Given this list of marker genes Anxa1, Pla2g1b, Abcc1, Drd4, Tnfrsf11a, Nmur2, Lhcgr, Cyp4a32, Ptges, P2rx7, Pla2g2d, Atp5pf, Hrh3, Cyp4a10 (NCBI Gene Id 13117), Abcc3, Pnpla8, P2ry2, Kiss1r, Nos2, Sstr4, Lep, Mapk9, Slco3a1, Slc22a1, Slc22a8, Pla2g4a, Pla2r1, Agtr2, Pla2g12b, Pla2g4f, Slc22a22, Ntsr1, Abcc10, Tnfsf11, Pla2g2e, Oc90, Pla2g12a, Syk, Il1a, Pla2g6, Cyp4a31, Drd3, Proca1 (NCBI Gene Id 71024), Slco4a1 (solute carrier organic anion transporter family, member 4a1), Slc22a6, Slco2a1, Pla2g2c, Pla2g5, Map2k6, Slc22a7, Slco2b1, Slc22a2, Il1b, Edn1, Acsl4, Ace, Abcc4, Avpr1b, Abcc6, Drd2, Pla2g3, Oxt, Ptgs2, Mif, Slc27a1, Hrh2, Bdkrb2, Pla2g2a, Pla2g2f, Nmb, Abcc2, Pla2g10, here is a description of the gene set: The directed movement of icosanoids into, out of or within a cell, or between cells, by means of some agent such as a transporter or pore. Icosanoids are unsaturated C20 fatty acids and skeletally related compounds. studied in species Mus musculus Mouse Gene Set: GOBP_ICOSANOID_TRANSPORT